Given this list of marker genes PTGS1, here is a description of the gene set: part of: Phase I - Functionalization of compounds species: Homo sapiens Arachidonic acid (AA) is a 20 carbon unsaturated fatty acid which is present in the lipid bilayer of all mammalian cells. AA is released from the membrane by phospholipases, thus making it available for conversion to bioactive lipids. The cyclooxygenase pathway is one of three pathways (the others being lipoxygenase and P450 monooxygenase pathways) that perform this conversion.\n\nThe enzyme that acts in the cyclooxygenase pathway is called cyclooxygenase (COX) or prostaglandin H synthase (PGHS). PGHS exhibits a dual catalytic activity, a cyclooxygenase and a peroxidase. The cyclooxygenase catalyzes the initial conversion of AA to an intermediate, prostaglandin G2 (PGG2) whilst the peroxidase converts PGG2 to prostaglandin H2 (PGH2) via a two-electron reduction. PGH2 is the intermediate for products that play critical roles in immune function regulation, kidney development and mucosal integrity of the GI tract.\n\nPGHS exists in two isoforms, 1 and 2 and both forms can perform the above reactions. Form 1 is constitutively expressed in most tissues and is involved in performing normal physiological functions. Form 2, in contrast, is inducible and is involved in critical steps of rheumatic disease, inflammation and tumorigenesis. Reactome Pathway: COX reactions